Given this list of marker genes Klb, Fgf15, here is a description of the gene set: Reactome Pathway: betaKlotho-mediated ligand binding electronically inferred by orthology from the curated human pathway part of: FGFR4 ligand binding and activation species: Mus musculus This event has been computationally inferred from an event that has been demonstrated in another species.<p>The inference is based on the homology mapping from PANTHER. Briefly, reactions for which all involved PhysicalEntities (in input, output and catalyst) have a mapped orthologue/paralogue (for complexes at least 75% of components must have a mapping) are inferred to the other species.